The following is a description of a gene set: from publication Cao J, O'Day DR, Pliner HA, Kingsley PD, Deng M, Daza RM, Zager MA, Aldinger KA, Blecher-Gonen R, Zhang F, Spielmann M, Palis J, Doherty D, Steemers FJ, Glass IA, Trapnell C, Shendure J (PMID 33184181) species: Homo sapiens Human Gene Set: DESCARTES_FETAL_PLACENTA_PAEP_MECOM_POSITIVE_CELLS The gene expression program underlying the specification of human cell types is of fundamental interest. The study authors generated human cell atlases of gene expression and chromatin accessibility in fetal tissues. For gene expression, the study authors applied three-level combinatorial indexing to >110 samples representing 15 organs, ultimately profiling ~4 million single cells. The study authors leveraged the literature and other atlases to identify and annotate hundreds of cell types and subtypes, both within and across tissues. Our analyses focused on organ-specific specializations of broadly distributed cell types (such as blood, endothelial, and epithelial), sites of fetal erythropoiesis (which notably included the adrenal gland), and integration with mouse developmental atlases (such as conserved specification of blood cells). These data represent a rich resource for the exploration of in vivo human gene expression in diverse tissues and cell types. Marker genes curated from the annotated cluster as represented in the Descartes Human Gene Expression During Development database., and this is the list of marker genes: ZNF19, ABCA4, KLK10, DOK5, LINC01502, TMEM252-DT, ENSG00000229192, RASD1, RNF180, PER2, CA12, LINC03033, SYT14, INHBB, LEKR1, ENSG00000231252, PKHD1, SLC15A1, KCNK2, RIMS2, MKLN1-AS, AHI1-DT, LINC01541, MUC1 (mucin 1, cell surface associated), SLC6A20, SAMD12, SLC34A2, ZPLD1, UGT2B7 (UDP glucuronosyltransferase family 2 member B7), UCA1, MACC1, RORC, DNAJB13, F2RL1, STK33, LCN2, ANKRD37 (NCBI Gene Id 353322), PDE7B-AS1, IL20RA, UGT8, LY86-AS1, VTCN1, HOXB-AS3, LINC02532, SLC18A2, GPX3, ENSG00000269043, SLC6A6, CFAP43, COMP, B4GALNT3, NMU, SNX29P2, F11-AS1, FAM135B, MUC20, WFDC2, MTF1, SLPI, BAIAP2L2, HOXB5, ELAPOR1, DLGAP1-AS3, LAMB3, CYS1, CDKL2, NAPSA, RXFP1, DNER, SLC6A12, AGR2, CX3CL1, GGT3P, ARG2, ATP2C2, ENPP5, MYO5C, C4BPA, ENSG00000262198, MAL, SCNN1A, TMEM101, DNAH7, HS6ST3, LINC00621, PIERCE1, CAPS, KIF12, ASRGL1, CCDC148, LINC01239, PIGR, LIF, IGSF11, C2CD4A, B4GALNT2, NXNL2, RIMKLB, LINC01301, FYB2, SEC14L6, IRX3, CP, LINC01470, LBP, SLC1A1, POU5F1, BDKRB2, DEPTOR, LRRC52-AS1, CATSPERB, ENSG00000243081, TNFAIP6, PTPRR, PAX2 (NCBI Gene Id 5076), SFN, EPCAM, LINC01913, OBP2A, FOXJ1, GALNT14, TMPRSS4, DCDC2, DNAH5, MRPS2 (mitochondrial ribosomal protein S2), MUC16, SVOPL, ETS2-AS1, GEM, SHROOM3, ARHGEF28, TSPAN1, OVOL2, PKDCC, TSPAN12, MFSD4A, DRAIC, ACMSD, NNMT, PAX8, LINC02888, TACSTD2, CLDN3, FAM227A, RAB2A, ERN1, GABRP, UBE2D2, EVC, KIZ, DEFB1, EHF, GRAMD1C, WDR72, SGPP2, PAEP, FAM9B, LINC01320, IL1RL2, B3GAT1-DT, ADGRF1, VWA3A, LRRIQ1, PRKAA2, LINC00871, TTC39A, PSORS1C3, FAM229B, SST, SIK2, KCNMB2, DRC3, HAP1